The following is a description of a gene set: Human Gene Set: REACTOME_DEVELOPMENTAL_LINEAGE_OF_PANCREATIC_DUCTAL_CELLS species: Homo sapiens Developmental Lineage of Pancreatic Ductal Cells, and this is the list of marker genes: KRT19 (keratin 19), COL11A2, LAMC2, HNF1B, COL5A2, LAMA1, COL2A1 (NCBI Gene Id 444981), SOX9, COL5A1, ONECUT1, LAMB3, ERICH5, CA2, LAMA2, LAMB1, PROM1, COL1A2, ANXA1, ANXA3, LAMC3, COL27A1, LAMA5, CD74, LAMA3, COL11A1, LAMA4, TFPI2, CLDN10, COL24A1, KRT17, KRT7, AQP1, PDX1, SLC4A4 (solute carrier family 4 member 4), NKX6-1, COL5A3, COL1A1, GATA4, KRT23, CFTR, LAMB2, VTN, ANXA2, YAP1, COL3A1, LAMC1, FOXA2, FN1